The following is a description of a gene set: Any process that results in a change in state or activity of a cell or an organism (in terms of movement, secretion, enzyme production, gene expression, etc.) as a result of a manganese ion stimulus. studied in species Mus musculus Mouse Gene Set: GOBP_RESPONSE_TO_MANGANESE_ION, and this is the list of marker genes: Ptgs2, Slfn14, Ireb2, Lrrk2, Eif2s1, Sod2, Tspo, Tfrc, Bace1, D2hgdh, Adam9, Atp13a2, Th, Atf4, A3galt2, Slc11a2, Atp7a